Given this list of marker genes Ube2v2, S100a10, Nfia, Gbp6, Cfap97, Braf, Mcts2, Rsf1, Sult1d1, Zcchc8, Slc16a7, Sap18b, Lrp2bp, Pcdhb19, Dcc, Cybrd1 (cytochrome b reductase 1), Rbms3, Pds5b, Rims2, Dach1, Myo5b, Kcnj13, Zfp532, Dpy19l2 (NCBI Gene Id 320752, dpy-19 like 2), Sacm1l, Crhbp, Pdik1l, Rcor2, Purb, Tdrd3, Flrt3, Arid1a, Slc25a46, Gria3, Lin7a, Vamp5, Itga8, Eif3a, Rnf180, Rapgef6 (Rap guanine nucleotide exchange factor (GEF) 6), Cisd2, Yy2, Rai14 (NCBI Gene Id 75646), Slc25a36, Taf7, Trappc13, Tada2b, Ccdc88a, Ccny, Folh1, Syt13, Mras, Rbm46 (RNA binding motif protein 46), Antxr2, Spry2, Egr2, Ckap2, Plch1, Plek2, Dock7, Corin, Zfp292, Tet1, Prkx, Fktn, Zfp397, Marchf5, Cdk13, Lrrtm2, Mtmr10, Med13, Sqstm1, Birc6, Nucb2, Sap18, Rhox9, Cops7b, Zdhhc20, Reck, Pdha1, Krtap9-21 (keratin associated protein 9-21), E2f4 (E2F transcription factor 4), Frrs1l, Cfap74, Odc1, Rab39b, Tubgcp3, Spice1, Sfmbt2, Zbtb14, A1cf, Vstm2a, here is a description of the gene set: studied in species Mus musculus Genes predicted to be targets of miRBase v22 microRNA mmu_miR_653_5p in miRDB v6.0 with MirTarget v4 prediction scores > 80 (high confidence targets). from publication Chen Y, Wang X (PMID 31504780) Mouse Gene Set: MIR_653_5P